Given this list of marker genes UGT1A3, CYP27C1, UGT2B4, LCN12, UGT1A6, UGT1A9, CRABP2, UGT2B7, SERPINA5, LRAT (NCBI Gene Id 9227), FABP5, UGT1A4, CYP26B1, RXRA, UGT1A10, UGT2B15, UGT1A1, CYP26C1, CYP26A1, RARA, UGT1A7, IGF2R, UGT2B17, CYP2W1, UGT1A8, CRABP1, NR2F2, here is a description of the gene set: studied in species Homo sapiens Human Gene Set: GOMF_RETINOIC_ACID_BINDING Binding to retinoic acid, 3,7-dimethyl-9-(2,6,-trimethyl-1-cyclohexen-1-yl)-2,4,6,8-nonatetraenoic acid.